The following is a description of a gene set: Palpitations Human Gene Set: HP_PALPITATIONS studied in species Homo sapiens A sensation that the heart is pounding or racing, which is a non-specific sign but may be a manifestation of arrhythmia., and this is the list of marker genes: CAV3, DLST, CCND1, NF1, JUP, SLC25A4, SCN9A, POLG, CITED2, PRKAR1A, VHL, NKX2-5, CACNA2D1 (NCBI Gene Id 781), GATA5, ABCC8, SDHA, TLL1, POLG2, GJA5, KCNA5, GYG1, SDHAF2, SCN1B, ATRX, HNF1A, GATA6, FH, EPAS1, JPH2, SDHD, UCP2, ACTC1, CLCNKB, ZNRF3, NUP155, ISCU, KIF1B, DNMT3A (DNA methyltransferase 3 alpha), TMEM126B, TMEM127, SCN2B, SLC12A3, CALM3, SLC25A11, SCN4B, MYL2, PRKAG2, THRB, CASQ2, CACNA1S, KCNJ5, SDHB, CALM2, KCNJ11, DTNA, PKP2 (NCBI Gene Id 93271), TWNK, KCNE1, MYZAP, TRDN, ADAMTS19, KLHL24, YY1, TECRL, SDHC, RRM2B, CNBP, CDKN2A, KCNQ1, TBX20, TMEM43, KCNJ18, NKX2-6, MDH2, TP53, CTNNB1, TTN, MYH6, PNPLA2, KCNJ2, GABRA3, CDH2, RYR2, SCN5A, GATA4, RET, DSG2, CDH23, KCND3, MEN1, CALM1, PITX2 (paired like homeodomain 2), KCNE2, KCNJ3, DSC2, GCGR, MYL3, MYOZ2 (NCBI Gene Id 53348), EMD, SLC4A3, MYL4, BVES, KCNH2, MYH7, SCN3B, ABCC9, TERT, NPPA, MAX